The following is a description of a gene set: Human Gene Set: GOBP_RESPONSE_TO_STILBENOID Any process that results in a change in state or activity of a cell or an organism (in terms of movement, secretion, enzyme production, gene expression, etc.) as a result of exposure to a stilbenoid. Stilbenoids are secondary products of heartwood formation in trees that can act as phytoalexins. Stilbenoids are hydroxylated derivatives of stilbene. They belong to the family of phenylpropanoids and share most of their biosynthesis pathway with chalcones. species: Homo sapiens, and this is the list of marker genes: KCNJ11, CD36, USP18, APOA4, CIDEA, LY6D, G6PC1, MIR21 (microRNA 21), IDI1, KCNJ8